The following is a description of a gene set: Regulation of MITF-M-dependent genes involved in cell cycle and proliferation Human Gene Set: REACTOME_REGULATION_OF_MITF_M_DEPENDENT_GENES_INVOLVED_IN_CELL_CYCLE_AND_PROLIFERATION studied in species Homo sapiens, and this is the list of marker genes: CDKN2A, CDK2, HDAC1, PLK1, CDKN1A, CTNNB1, CDC25B, TCF7, CCNB1, TCF7L2, MITF, TBX2, CCND1 (cyclin D1), MET, LEF1, HINT1, SIN3A, TCF7L1